The following is a description of a gene set: part of: Ribosome-associated quality control This event has been computationally inferred from an event that has been demonstrated in another species.<p>The inference is based on the homology mapping from PANTHER. Briefly, reactions for which all involved PhysicalEntities (in input, output and catalyst) have a mapped orthologue/paralogue (for complexes at least 75% of components must have a mapping) are inferred to the other species. Reactome Pathway: ZNF598 and the Ribosome-associated Quality Trigger (RQT) complex dissociate a ribosome stalled on a no-go mRNA species: Mus musculus electronically inferred by orthology from the curated human pathway, and this is the list of marker genes: Rpl23a, Rps3a1 (ribosomal protein S3A1), Rpl12, Rps18, Rps2, Rpl39, Rps4x, Rps12, Rpl15, Rpl13, Rpl9, Rpl37, Rps26, Rpl6, Rps19, Rpl3l, Rps15, Rpl37rt, Rps11, Ascc3, Rps13, Rps27l, Ubb, Rpl27, Rpl11, Fau, Rpl29, Rplp2, Rpl26, Rps8, Rpl36al, Rpl36a, Rpl27a, Rps6, Rpl39l, Rpl38, Zfp598, Rpl19, Ube2d1 (ubiquitin-conjugating enzyme E2D 1), Rps17, Rpl14 (ribosomal protein L14), Rps24, Rps10, Rpl3, Rps7, Rpl7, Rpl4, Rps23 (ribosomal protein S23), Rps28, Rpl24, Rps20, Rps5, Rps25, Rps27a, Rpl18a, Rps9, Rpl37a, Rpl18